The following is a description of a gene set: studied in species Homo sapiens from publication Good KL, Avery DT, Tangye SG (PMID 19124732) Enhanced secondary Ab responses are a vital component of adaptive immunity, yet little is understood about the intrinsic and extrinsic regulators of naive and memory B cells that results in differences in their responses to Ag. Microarray analysis, together with surface and intracellular phenotyping, revealed that memory B cells have increased expression of members of the TNF receptor, SLAM, B7 and Bcl2 families, as well as the TLR-related molecule CD180 (RP105). Accordingly, memory B cells exhibited enhanced survival, proliferation and Ig secretion, as well as entered division more rapidly than naïve B cells in response to both T-dependent and T-independent stimuli. Furthermore, both IgM and isotype switched memory B cells, but not naïve B cells, co-stimulated CD4+ T cells in vitro through a mechanism dependent on their constitutive expression of CD80 and CD86. This study demonstrates that upregulation of genes involved in activation, co-stimulation and survival provides memory B cells with a unique ability to produce enhanced immune responses and contributes to the maintenance of the memory B cell pool. Human Gene Set: GSE13411_SWITCHED_MEMORY_BCELL_VS_PLASMA_CELL_DN Genes down-regulated in comparison of Ig isotype switched memory B cells versus plasma cells., and this is the list of marker genes: COX6A2, EHHADH, MCHR1, AXL, DNAJC1, BMAL2, GCGR, KLK3, G6PC3, HGD, CTLA4, NR5A1, ITGA2, EPB41L1, DUOX2, DGCR5, IGKV3-20, SPOCK1, ARSA, KDELR3, RET, GANAB, AQP3, CDT1, H2BC6, OR1G1, SERPINA2, DOT1L, DPY19L1, NKAIN1 (sodium/potassium transporting ATPase interacting 1), GSG1 (NCBI Gene Id 83445), PPP1R26, CTH, GTF3C5, SULF1, TNFRSF17, MGAT1, EXT1, HEY1, PKP3, ITGBL1, BBOX1, GSTP1, B9D1, GZMA, TARP, IL5RA, IGLV3-19, PGM3, IGHMBP2, RASIP1, CCR10, KAZN, SLC17A5, PSRC1, ICAM1, IGLJ3, CYP1A1, RTN1, FKBP11, PPIB, DUSP7, ADGRA3, BLMH, PCSK5, RCN3, PDK1, GPC4, PRDM1, SPP1, ZNF460, AANAT, H4C13, APOL6, PLPP2, EMC9, H2AC16 (NCBI Gene Id 8332), PRPH, CDH15, CBARP, FOLH1, ZNF215, OPTN, BRCA1, RNF208, AKR1C3, OVOL1, CACNA1F, ACTL7A, LAGE3, PARPBP, GJA1, RND1, SCN7A, NCALD, UBE2C, TH, THAP4, H2BC17, SMAD5-AS1 (NCBI Gene Id 9597), POLD1, ELL, MICALL1, CARMIL1, APOL1, SLC25A4, ALDH7A1, CD2, TSSK2, GPRC5D, SPICE1, HTN1, CDADC1, MORC1, TAAR5, LIME1, H2AC14, GSTM3, FAM149A, KDELR2, HDLBP, GAS8 (NCBI Gene Id 2622), RARB, SLAMF7, SARS2, EXO1, H2BC5, MT1E, CYP2E1, MRPL12, GUCY1A2, CDC25A, RRBP1, ASRGL1, FICD, PKMYT1, PLA2R1, MYF6, TPX2, SMPX, GMPPB, PFKFB1, AGTR2, KLHL4, CDK1, TIMP2, ASF1B, DOLK, LYPLA2, CLINT1, OR7E87P, SCARB1, CRELD2, ATP8B2, GHR, RAD54L, TSHR, DYNC1LI2 (NCBI Gene Id 1783), RYBP, MARK2, RAP1GAP2, BET1L, MANSC1, FOXD3, MASP1, MMP15, KIFC1, CD38, BTN2A3P, AKAP12, FKBP2, COPZ2, CDH17, IGLL3P, SMPDL3B, STC1, SPAG5, OR10H1, MCF2, MYO1C, PTPRT, LRRN3, KCNA3, VEGFA, IGKC, GPR50, DARS2, ADGRE3, KCNMB1, OR2H1, METTL1 (methyltransferase 1, tRNA methylguanosine), TRIM49, IFT70A, CLIC2, GSTM1